Given this list of marker genes Vmn2r65, Vmn2r1, Vmn2r83, Vmn2r26, Vmn2r120, Vmn2r82, Vmn2r81, here is a description of the gene set: Mouse Gene Set: GOMF_G_PROTEIN_COUPLED_OLFACTORY_RECEPTOR_ACTIVITY studied in species Mus musculus Combining with an odorant and transmitting the signal across the membrane by activating an associated G-protein; promotes the exchange of GDP for GTP on the alpha subunit of a heterotrimeric G-protein complex.